Given this list of marker genes MCM5, ACTL6A, UCN, NFRKB, TIPIN, DBF4B, BAZ1A, ESCO1, RUVBL2, WAPL, CDC7, NUGGC, JADE3, S100A11, HCRT, PTK6, ID3, ACTR8, CDT1, MCM7, ENDOG, CCNA2, JADE2, ZMPSTE24, INO80, POLE3, CAMSAP3, ORC5, KAT7, TTF1, RBBP6, ING5, PCNA, WEE1, CDC6, FAF1, TP53, KCTD13, PDS5A, ACTR5, CDKN1A, SMC3, WIZ, ATF1, TSPYL2, GDF2, CHRAC1, RAD17, INO80C, MCM6, INO80E, DNA2, TIMELESS, E2F7, DSCC1, CTC1, TICRR, AICDA, DACH1, ATAD5, CIZ1, EHMT2, MCM3, NUCKS1, MCM2, MCIDAS, TNFAIP1, SMARCA5, FBXO5, BCL6, SSBP1, EREG, RUVBL1, EGFR, DYNLL1, AGER, TFPT, GMNC, MCM4, METTL4, ATRX, GTPBP4, INO80D, YY1, CDKN1B, INO80B, OBI1 (ORC ubiquitin ligase 1), BRPF3, CDC25A, CDK2, WRNIP1, LIG3, MCRS1, ESCO2, GLI1, ATR, NPM2, FGFR1, JADE1, NBN, ENPP7, ANKRD17, USP37, ORC3, STN1, CDK1, SENP2, ACVRL1, GLI2, DBF4, CACYBP, MEAF6, E2F8, TERF1, GMNN, UCHL5, DHX9, SLFN11, ZBTB38, here is a description of the gene set: Any process that modulates the frequency, rate or extent of DNA replication. Human Gene Set: GOBP_REGULATION_OF_DNA_REPLICATION species: Homo sapiens